The following is a description of a gene set: species: Mus musculus Catalysis of a ring closure reaction. Mouse Gene Set: GOMF_CYCLASE_ACTIVITY, and this is the list of marker genes: Guca1b, Gucy2c, Adgrv1, Adcy4, Gnaz, Gucy1b1, Adcy2, Gucy1b2, Dglucy, Guca2a, Npr2, Gucy1a1, Adcy7, Rcl1, Adcy1, Calm1, Adcy10, Npr1, Tkfc, Gucy2g, Rtca, Gnas, Gucy1a2, Raf1, Adcy5, Gnai1, Gucy2d, Grm7, Adcy6, Adcy8, Calm2, Nherf4, Calm3, Adcy3, Guca2b, Guca1a (guanylate cyclase activator 1a (retina)), Adcy9 (adenylate cyclase 9), Gucy2e, Gucy2f, Rgs2, Ncs1